The following is a description of a gene set: studied in species Homo sapiens Human Gene Set: RORA1_01 Genes having at least one occurrence of the motif NWAWNNAGGTCAN in the regions spanning 4 kb centered on their transcription starting sites. This matches the RORA transcription factor binding site V$RORA1_01 (v7.4 TRANSFAC)., and this is the list of marker genes: DBP, NOL4, ABHD3, CCDC88A, LINC00575, CHRDL1, PPP2R5D, CALCA, ZMAT4, COLQ, UHRF2 (ubiquitin like with PHD and ring finger domains 2), NDRG2, FBXW4, TTL, NEFM, ERN1, ESPN, ADCYAP1, NAV1, LDB2, TDRP, IL17RE, VAMP1, TSPAN7, PSIP1, HOXB3, SUCLA2, FSBP, MRPL27, WDR72, ATP5MF, RASAL1 (NCBI Gene Id 8437), CNTFR, RBMS1, GRIA1, STRADB, GID4, IL7, HDAC9, H4C3, VASP, TPM3, ZNF516-DT, SORCS1 (sortilin related VPS10 domain containing receptor 1), RTL9, SCMH1, JAKMIP2, SAG, ATP8B2, CDHR1, CX3CL1 (NCBI Gene Id 6376), NFATC3, STAC2, SMPX, ACOXL, MYL3, R3HDM2 (R3H domain containing 2), SOCS2, KHDRBS2, NRSN2, MEF2C, IP6K2, HSPD1, IVNS1ABP, CLRN1, NCKAP5, ATP5MC1, PABIR2, PIM1, SPAG9, ESRRB, GPR161, SLC8A3, HSPE1, LMO3, ATP1B4, UBL3, TIMM9, ZFP36L1, SPTAN1, ZNF296, DTNB, FBXW7, PKP3, NFYA, CLIP1, JARID2 (NCBI Gene Id 3720), CAMKK2, CTH, TSPEAR, RBFOX1, RASA4, KIAA0586, CHD2, PLA2G5, GRIK3, SLC22A6, LCA5, SOX15, PALS2, TRAP1, NEO1, PBXIP1, PITPNM1, MLLT6, SNTG1, GABARAPL1, SLA, AMY2A, PHF5A, KDM3B, ZDHHC21, CYP39A1, STK38 (NCBI Gene Id 11329), CNTF, YTHDF2, PPP2CA, KRT9, PCDH18, NPAS2, RNF144B, NAA25, HOXA3, TRMT10A, VNN3P, CXXC5, URGCP, GPRIN3, DCUN1D4 (defective in cullin neddylation 1 domain containing 4), CCDC92 (coiled-coil domain containing 92), MCC, IRAG1, BTBD3, MPC2, SEMA3F, NRP1, FHDC1, USP8, BZW2, IL22, OGFOD1 (NCBI Gene Id 55239), B3GALT2 (NCBI Gene Id 90195), VAMP2, CNTN2, HCN1, RCOR1, ATPAF2, PPP4R3A, ATP6AP2, MPP3, CMTM6, MSI2, YWHAQ, DTNA, NTF3, AOC2, LARGE1, ZRANB1, GK, TAB3, EXTL2, TMEM52B, ACSL4, RIPOR1 (RHO family interacting cell polarization regulator 1), EME1, FBXL22, AFG3L2, CAMK2B (NCBI Gene Id 816), TNRC6A, EGFLAM, ARL6IP1, ZNF687 (NCBI Gene Id 57592), SHH, RTN3, KCNAB3, SARNP, ATP1B2, JMJD1C, HSPA9, TCF7, RYR1, TTBK2, GRM1, GTF2IRD1, DACT1, FGF9, ARF6, RLIM, CSAD, OARD1, BCL9, NRL, GEMIN7, SPOCK2, ZFAND5, EFNA3, SATB1, AP3D1, NR2F2, KIF5A, ANGPT1, SYNE1, STEAP2, LPAR4, ASPH, FBXO30, UBAC1 (UBA domain containing 1), CREB1, MYLK, STAU1, ITGAX (integrin subunit alpha X), LCN2, FLI1, MYB, ONECUT2 (NCBI Gene Id 9480), BMAL1, NOG, SLC18A2, ELAVL4, NAA50, ABRA, GLI1, CNTLN, TMEM35A, SOCS4, RAB3A, NELL2, ENO3, TAOK2, CACNA1A, ZNF644, ATP6V1A, ARX, GALT, ACO2, CNTN6, MPRIP, IL17F, SHISA5, ABAT, PACSIN1 (NCBI Gene Id 57564), CACNB2, CHST1, SLC25A27, MATK (NCBI Gene Id 4145), RGS6, EPHA7, SLC4A7